The following is a description of a gene set: Human Gene Set: FAN_EMBRYONIC_CTX_NSC_1 species: Homo sapiens from publication Fan X, Dong J, Zhong S, Wei Y, Wu Q, Yan L, Yong J, Sun L, Wang X, Zhao Y, Wang W, Yan J, Wang X, Qiao J, Tang F (PMID 29867213), and this is the list of marker genes: RPL36A, DUSP6, ZEB1, VIM, RARRES2, MEF2C, PDLIM1, CCDC80, CCND2, GAD1, DLL3, SPRY1, PANTR1, HNRNPA1, FOS, MCM4, NME1, DSCAM